Given this list of marker genes NS, here is a description of the gene set: Since the presence of intracellular dsRNA serves as the signal for virus infection and triggers host interferon (IFN) synthesis the simplest model for viral NS1 protein function is that it sequesters dsRNA and thus prevents the downstream signaling required to activate IRF-3, NF-kB and AP-1. These findings are strongly supported by mutational analyses of NS1 that indicate that the IFN antagonist properties of NS1 depend on its ability to bind dsRNA. However, a compensatory mutation (S42G), which was acquired during the passaging of the mutant RNA-binding virus, results in partial restoration of wild-type phenotype but does not restore RNA binding. This indicates that the ability of NS1 to inhibit IFN synthesis is not solely dependent on dsRNA binding and that additional mechanisms may be involved. species: Homo sapiens part of: Inhibition of Interferon Synthesis Reactome Pathway: Inhibition of IFN-beta